Given this list of marker genes Kcnmb2, Kcnmb4, Kcnn2, Kcnk18, Kcnn1, Pkd2l1, Tmem38a, Kcnmb3, Kcnu1, Kcnma1, Kcnmb1, Kcnn3 (NCBI Gene Id 140493), Kcnn4, here is a description of the gene set: Mouse Gene Set: GOMF_CALCIUM_ACTIVATED_POTASSIUM_CHANNEL_ACTIVITY studied in species Mus musculus Enables the transmembrane transfer of a potassium cation by a channel that opens when a calcium cation has been bound by the channel complex or one of its constituent parts.